Given this list of marker genes SLC2A9, SARS2, ATP5F1B, SEC61A1, CTNS, C3, DBH, AVPR2, CD46 (CD46 molecule), SLC22A12, THBD, CFI, CFHR1, CFH, ERCC8, MRPS7, UMOD, CFB, PIGA, ADAMTS13, ERCC4, CFHR3, FAN1, ERCC6, ELP1, here is a description of the gene set: Abnormal blood urea nitrogen concentration Human Gene Set: HP_ABNORMAL_BLOOD_UREA_NITROGEN_CONCENTRATION Any deviation from the normal concentration of urea nitrogen in the blood. species: Homo sapiens